Given this list of marker genes CTRC (NCBI Gene Id 11330), CFTR, SPINK1, PRSS2, PRSS1, here is a description of the gene set: Cyst-like space not lined by epithelium and contained within the pancreas. Pancreatic pseudocysts are often associated with pancreatitis. Pancreatic pseudocyst Human Gene Set: HP_PANCREATIC_PSEUDOCYST species: Homo sapiens